Given this list of marker genes TCF12, HOXC4, ALX4, POU3F3, OLIG2 (NCBI Gene Id 10215), PRRX1, GATA3, CEBPA, PAX6, HOXA3, DLX5, MEOX1, here is a description of the gene set: Human Gene Set: GOMF_HMG_BOX_DOMAIN_BINDING Binding to an HMG box domain, a protein domain that consists of three helices in an irregular array. HMG-box domains are found in one or more copies in HMG-box proteins, which form a large, diverse family involved in the regulation of DNA-dependent processes such as transcription, replication, and strand repair, all of which require the bending and unwinding of chromatin. studied in species Homo sapiens